The following is a description of a gene set: Any process that activates or increases the frequency, rate or extent of natural killer cell chemotaxis. species: Homo sapiens Human Gene Set: GOBP_POSITIVE_REGULATION_OF_NATURAL_KILLER_CELL_CHEMOTAXIS, and this is the list of marker genes: CCL3, CCL7, XCL1, CCL5, CCL4